The following is a description of a gene set: studied in species Mus musculus Mouse Gene Set: chr14A3, and this is the list of marker genes: Anxa7, Gm20242, Plac9, Adk (adenosine kinase), Tasor, Lrtm1, 4930428N03Rik, Gm7591, Gm35217 (NCBI Gene Id 102638723), Gm30363, Il17rd, Selenok, 1810062O18Rik, Kcnk16, Gm10248, Slmap, Slmapos2 (NCBI Gene Id 71106), Gm2670, Arhgef3, Gm31392 (NCBI Gene Id 102633608), Ecd, D14Ertd670e, Myoz1, Gm6128, Gm18215, 1700054O19Rik, Gm7633, Ndst2, Samd8, Gm7565, 6230400D17Rik, Saysd1, 4930405A10Rik, Mir7210, Lrmda, Gm18398, Cacna2d3, 9930004E17Rik, Gm7352, Zmiz1os1, Anxa11os, Gm35164, Gm15935, Gm18079, Gm18577, Dennd6a, Ppif, Wnt5a, Gm45645, Dusp13b, Gm18276, Gm34059, Zswim8, Ap3m1, Cfap70, Gm17747, Gm6158, Appl1, Fam149b, 4930542C16Rik, Dnajc9, Plau, Arf4, Gm2244, Duxbl1, Ccdc66, Arf4os, Gng2, Nudt13, Mir7672, Gm2237 (NCBI Gene Id 100039441), A430057M04Rik, Gm5670, Rps24, Gm2048, Gm24031, Mss51, Mir3075, Gm41118, Comtd1, Mir6946, Gm6043, Dnah12, Tmem254, Gm41115, Gm48105, 4930519K11Rik, Sec24c, Gm41102, Gm7473, Gm7604, Usp54, Kcnma1 (NCBI Gene Id 70528, potassium large conductance calcium-activated channel, subfamily M, alpha member 1), Ppifos, Mrps16, Gm18578, Rtraf, Gm24912, Vdac2, Polr3a, Pde12, Gm2178, Kat6b, Gm47814, Cphx1, Gm25697, Gm10398, Zcchc24, Nid2, Zmiz1, Zfp503, Synpo2l, Chchd1, Fut11, Vcl, Asb14, Gm35281, Gm19034, Gm7371, Dusp29, Gm38408, 4930469B13Rik, Gm23502, Ppp3cb, Anxa11 (annexin A11), 5430425E15Rik, Camk2g, Gm5458, Gm30108, Kcnk5, Gm7480, Erc2, Gm17030 (predicted gene 17030), Gm41109, 2810402E24Rik, Gm30054, E330034G19Rik, Hesx1 (homeobox gene expressed in ES cells), Gm46443, 7330404K18Rik, Gm32123, Dlg5, Gm19013, Gm36704, 4931407E12Rik